The following is a description of a gene set: Human Gene Set: HE_LIM_SUN_FETAL_LUNG_C1_PROXIMAL_SECRETORY_1_CELL Proximal secretory 1 from publication He P, Lim K, Sun D, Pett JP, Jeng Q, Polanski K, Dong Z, Bolt L, Richardson L, Mamanova L, Dabrowska M, Wilbrey-Clark A, Madissoon E, Tuong ZK, Dann E, Suo C, Goh I, Yoshida M, Nikolić MZ, Janes SM, He X, Barker RA, Teichmann SA, Marioni JC, Meyer KB, Rawlins EL (PMID 36493756) species: Homo sapiens, and this is the list of marker genes: ELAPOR1, MUC15, CXCL1, SPDEF, SIX1, CRYM, CFH, LIPH, CAPN8, SOD3, EFHD1, CYTL1, KRT4, ATP2C2, CA10, NT5E, HCAR2, AGR3, PLEKHS1, CP (ceruloplasmin), LYPD6B, CAMK1D, FAM3D (NCBI Gene Id 131177), NXPH4, NEGR1 (NCBI Gene Id 257194), ST8SIA4, ACKR3, ATP2A3, NTM, NDUFA4L2, HS3ST1, SLITRK6, KDR, B3GALT5, GALNT12, CHST9, PLPP2, SCGN, ANXA1, FNBP1, LINC01645, WNK2, ANKRD35, SLPI, MT3, KLK11, HPGD, DPYSL3, ADAM28, SCNN1A, GK, SLC15A2, MET, EHF, ZNF385B, GSTA1 (NCBI Gene Id 2938), SULT2B1, ISL1, RUNX1 (RUNX family transcription factor 1), S100A9, BCL6, KLK10, TSPAN1 (tetraspanin 1), FCGBP, BRINP2, MUC5B, ARFGEF3, LCN2, JAKMIP2, PLAAT4, CTSW, TNFSF10, S100P, STEAP4, VTCN1, SFTPA2, SFTA1P, TMEM150C, ITIH2, IRAG2, CCNO, MLPH, GRHL1, CX3CL1, SCGB3A1, CXCL2, CH25H, ADRA2A, TMEM45A, TFPI, SCGB1A1, PLAT, CAPS (NCBI Gene Id 828), CXCL8, CXCL3, TIAM1, ST6GALNAC1 (NCBI Gene Id 55808), SERPINA1, RHOV, CEACAM6, RNF150, WIPI1, MUC16, TIMP1, TOX3, LUZP2, MUC20, SPINK5, MEG3